The following is a description of a gene set: studied in species Mus musculus Mouse Gene Set: GOBP_PROTEIN_LOCALIZATION_TO_EXTRACELLULAR_REGION Any process in which a protein is transported from one specific location in the extracellular region to another, or maintained in a specific extracellular location., and this is the list of marker genes: Ccn3, Ptpmt1, Ptger3, Comp, Ndufaf2 (NCBI Gene Id 97896), Abat, Srebf1, Prkcq, Adcy8, Vip, Gpr27, Glud1, Clock, Trpa1, Mia2, Sec24a, F2r, Snord32a, Ap1s1, Doc2b, Mir130a, Rfx6, Pparg, Lepr, Agt, Anxa5, Htt, Il1rn, Uqcc2, Kcnq1, Rsad2, F2rl2, Tmed10, Rims2, Ptprn2, Tmed2, Tgfb2, Vgf, Copg2, Adam9, Mup1, Cyb5r4, Ang, Ankrd1, C2cd2l, Sidt2, Irs1, Cnr1, Afm, Epha5, Ins1, Fam3b, Sco1, Nr1h4, Pfkl, Myrip, Hnf1a, Cd38, Tfap2b, Idua, Lep, Kcnb1, Rptor, Pard6a, Pla2g6, Gipr, Cacna1c, Mup2, Oga, Snord35a, Per2, Nos1 (NCBI Gene Id 76730), Vps35, Ffar1, Camk2n1, Glp1r, Trpm2, Map4k4, Baiap3, Ildr2, Arrb1, Lmf1, Gpr39, Ifnb1, Acsl4, Gcg, Tgfb1, Neo1, Cd200, Adra2a, Foxa2, Mtnr1a, Sybu, Tmem258, Il12a, Fto, Alox5, Fbn2, Gzmb, Ucp2, Pck2, Ptpn11, Lrrc8a, Prkce, Pick1, Slc8b1, Ensa, Kcnj6, Rap1gds1, Gnptab, Pde3b, Hnf1b (NCBI Gene Id 21410), Ghsr, Crhr2, Fbn1, Igf1, Fgg, Ppp3ca, Arf6, Ins2 (insulin II), Bmal1, Syt7, Arf1, Midn, Pfkm, Mup5, Glul, C1qtnf5 (NCBI Gene Id 235312), Tango6, Nbl1, Ap1m2, Tiam1, Cacna1e, Abcc8, Inhbb, Slc16a1, Svbp, Sirt6, Gnaz, Idh2, Jagn1, Sucnr1, Rab3a, Pde4c, Ier3ip1, Acvr1c, Stx4a, Ifng, Ttn, Gsdmd, Rhbdf1, Trpc1, Rapgef4, Snx19, Il1a, Capn10, Sirt4, Cwh43, Kcnj8, Rac1, Gper1, Tlr4, Hmgn3, Psap, Vamp8, Apbb3, Srcin1, Tmed10-ps (transmembrane p24 trafficking protein 10, pseudogene), Lrp5, Tmem167, Rcn3 (NCBI Gene Id 78587), Tnf, Rbm4, C1qtnf12, Unc13b, G6pc2, Rab11fip3, Mir200a, Stim1, Park7, Mlxipl, Trpm5, Gnaq (NCBI Gene Id 71788), Adtrp, P2rx7, Mttp, Cd2ap, Rab11fip2, Golph3l, Kcnn4, Fga, Vegfc, Apoe, Trh, Mc4r, Sirt3, Nkx6-1, Gna11, Sfrp1, Or51e2, Anxa7, Frmd4a (FERM domain containing 4A), Madd, Rph3al, Il6, Erp29, Sstr5, Ucn3, Sncg, Rab11fip1, Mup3 (NCBI Gene Id 17842), Myom1, Nrros, Bloc1s3, Pdx1, Prkar1a, Raf1, Ahi1 (Abelson helper integration site 1), Cckar, Mia3, Gja1, Eny2, Efna5, Gpr119, Abcg1, Fam3d (NCBI Gene Id 218702), Mon1a, Brsk2, Abca12, Nnat (NCBI Gene Id 99314), Rbp4, Ccl5, Aacs, Gck, Hps1, Myh10, Mafa, Myh9, Ptbp1, Olfm2, Hcfc1, Copg1, Dynll1, Bloc1s6, Piwil4, Tunar, Chga, Cela2a, Neurod1, Krt20, Golph3, Il13, Irs2, Pde8b, Nlgn2, Fkbp1b (NCBI Gene Id 14226), Foxo1, Psmd9, Pafah1b1, Gprc6a, Nos2, Arfip1, Tmem132a, Ptger4, Ppp3cb, Snord33, Sirt1, Cer1, Slc30a8, Ube2q1, C1qtnf3, Cbln1, Steap3, F2rl1, Ccdc186, Eipr1, Plek, Slc2a2, Pcsk1, Rhbdd3, Akap5, Exph5, Cpt1a, Cacna1d, Hif1a, Comt, Tcirg1, Cplx1, Cltrn, Slc12a2, P3h1, Tgfb3, Vps13a, Prkaca, Syt9, Slc4a8, Fam3a, Ptprn, Lyst, Snap25, Prkn, Egfr, Rab11b, Hmga1, Atp13a2, Trem2, Klf7, Nr1h3, Npff, Cartpt, Pclo, Ffar3, Myo18a, Stxbp5l, Serp1, Wls, Drd4, Drd3, Nadk, Mup4, Oxct1, Ptpn23, Clstn3, Slc25a22, Kcnj11, Mup11, Dph3, Selenot, Sytl4, Hadh (NCBI Gene Id 99932, hydroxyacyl-Coenzyme A dehydrogenase), Filip1l, Birc5, Cavin1, Cyp51, Vsnl1, Osbp, Zfp384, Nr1h2, Gpld1, Il12b, Dand5, Gja5 (NCBI Gene Id 70659), Ang6, Dnm1l, Snord34, Ednrb, Tvp23a, Apbb1, Jak2, Drd2, Prf1, Crh, Ppard, F2, Rhbdf2, Uts2, Orai1, Isl1, Tardbp, Bglap2, Itpr1, Pfkfb2, Cbln4 (cerebellin 4 precursor protein), Arfgap3, Il1b, Casp1, Slc9b2, Nmu, Rab27a, Ncoa6, Fgb, Gnao1, Abca1, Malrd1, Ang5 (angiogenin, ribonuclease A family, member 5), Zbed6, Mmp13, Kif5b, M6pr, Ano1, Adcy5, Smad2, Ep300 (NCBI Gene Id 328572), Ghrl, Porcn, Bsg, Dgat1, Prkcb, Rfx3, Adora2a, Cdk16, Nagpa, Tlr2, Negr1, Bad, Gip, Cask, A1cf, Mcu, B3glct, Gpr68, Syt4, Mtnr1b (melatonin receptor 1B), Ltbp1, Hcar2, Nr1d1, Ap1b1, Ang2, Sergef (NCBI Gene Id 27414), Chrm3, Mir410, Sox4, Nr0b2, Sri, Ap1g1, Casr, Tacr2, Pde1c, Atg7, Gnai1, Acvr2b (activin receptor IIB), Tcf7l2, Stxbp4, Hps6, Tm7sf3, Agtr1a, Myo5a, Sel1l, Dnajc1, Mpc2, Tbc1d1, Myt1, Ffar2, Ang4, Rab34 (NCBI Gene Id 19376), Stx1a, Stxbp3, Trpm4, Gnas, Adcyap1, Ppid, Plcb1, Cplx3, Tango2, Lrp1, Rest, Hmgcr, Cftr, Anxa1, Oprm1, Blk (NCBI Gene Id 12143), Hnf4a, Pim3, Lrrc32, Tvp23b, Ptprv, Rab11fip5, Slc18a2, Ppia